Given this list of marker genes HCFC1, GBX2, CCNB1, MKI67, RNF2, USP22, BUB1, here is a description of the gene set: Genes whose over-expression is associated with the risk of death in multiple cancer types from publication Glinsky GV, Berezovska O, Glinskii AB (PMID 15931389) species: Mus musculus Human Gene Set: GLINSKY_CANCER_DEATH_UP Activation in transformed cells of normal stem cells' self-renewal pathways might contribute to the survival life cycle of cancer stem cells and promote tumor progression. The BMI-1 oncogene-driven gene expression pathway is essential for the self-renewal of hematopoietic and neural stem cells. We applied a mouse/human comparative translational genomics approach to identify an 11-gene signature that consistently displays a stem cell-resembling expression profile in distant metastatic lesions as revealed by the analysis of metastases and primary tumors from a transgenic mouse model of prostate cancer and cancer patients. To further validate these results, we examined the prognostic power of the 11-gene signature in several independent therapy-outcome sets of clinical samples obtained from 1,153 cancer patients diagnosed with 11 different types of cancer, including 5 epithelial malignancies (prostate, breast, lung, ovarian, and bladder cancers) and 5 nonepithelial malignancies (lymphoma, mesothelioma, medulloblastoma, glioma, and acute myeloid leukemia). Kaplan-Meier analysis demonstrated that a stem cell-like expression profile of the 11-gene signature in primary tumors is a consistent powerful predictor of a short interval to disease recurrence, distant metastasis, and death after therapy in cancer patients diagnosed with 11 distinct types of cancer. These data suggest the presence of a conserved BMI-1-driven pathway, which is similarly engaged in both normal stem cells and a highly malignant subset of human cancers diagnosed in a wide range of organs and uniformly exhibiting a marked propensity toward metastatic dissemination as well as a high probability of unfavorable therapy outcome.